The following is a description of a gene set: Reactome Pathway: Signalling to ERKs part of: Signaling by NTRK1 (TRKA) species: Homo sapiens Neurotrophins utilize multiple pathways to activate ERKs (ERK1 and ERK2), a subgroup of the large MAP kinase (MAPK) family, from the plasma membrane. The major signalling pathways to ERKs are via RAS, ocurring from caveolae in the plasma membrane or from clathrin-coated vesicles, and via RAP1, taking place in early endosomes. Whereas RAS activation by NGF is transient, RAP1 activation by NGF is sustained for hours., and this is the list of marker genes: CRKL, MAP2K2, KRAS, KIDINS220, MAP2K1, RIT2, MAPKAPK3, MAPK11, RIT1, SHC1, MAPK3, CRK, MAPK12, MAPK14, RALA, RAPGEF1, FRS2, BRAF, NGF, SRC, RALB, RALGDS, SHC2, NTRK1, HRAS, RAP1A, MAPK13, GRB2, SHC3, MAPK1, MAPKAPK2, YWHAB, NRAS, SOS1